The following is a description of a gene set: Any process that reduces the pH of the vacuole, measured by the concentration of the hydrogen ion. studied in species Mus musculus Mouse Gene Set: GOBP_VACUOLAR_ACIDIFICATION, and this is the list of marker genes: Atp6v0a2, Atp6v0a4, Cln3, Lamp2, Grn, Snapin, Slc11a1, Ccdc115, Atp6v1b1, Creg1, Clic4, Lamp1, Atp6v0c, Tmem9, Tmem106b, Dmxl2, Ppt1, Atp6v0d1, Dmxl1, Atp6v1b2, Atp6v0a1, Tcirg1, Cln6, Tmem199, Cln5, Atp6ap2, Atp6v0d2